The following is a description of a gene set: species: Homo sapiens Human Gene Set: GOBP_REGULATION_OF_RECEPTOR_INTERNALIZATION Any process that modulates the frequency, rate or extent of receptor internalization., and this is the list of marker genes: DTNBP1, ANXA2, RIN3, WNT3A, DRD2, UBQLN2, USP46, SYT17, APLN, NTF3, ANKRD13A, HIP1, ATXN2, ARRB2, ARRB1, SFRP4, SH3GL2, DKK1, LRRTM2, PICK1, ITGB3, MAGI2, NRG1, FLOT1, MTMR2, TBC1D5, USP6, APP, SDCBP, AP2M1, CD63, GREM1, ATAD1, MKLN1, MDM2, NCDN, ARC, ARAP1, RNF220, APELA, OPHN1, RSPO1, APLNR, ANGPT1, GSG1L, SYK, TAMALIN, PLCG2 (phospholipase C gamma 2), EGF, RABEP1, RALA, SELE, WDR54, VEGFA, NUMB, HPCA, LRRTM1, VAC14, SCRIB, DLG4, DRD4, PCSK9, AHI1, FMR1, INSR, ANKRD13D, PPP3R1, LPAR1, MIR199A1, LRPAP1, CBLB, HAMP, ANKRD13B, SUSD4, EFNB2, GH1, ARF1, NECAB2